The following is a description of a gene set: studied in species Homo sapiens A discrete abnormal tissue mass that protrudes into the lumen of the intestine and is attached to the intestinal wall either by a stalk, pedunculus, or a broad base. Intestinal polyp Human Gene Set: HP_INTESTINAL_POLYP, and this is the list of marker genes: POLD1, MTOR, PIK3CA, KRAS, BUB3, PMS1, SDHC, BUB1B (BUB1 mitotic checkpoint serine/threonine kinase B), CTNNB1, STK11, MSH6, CHEK2, ENG (NCBI Gene Id 2022), BUB1, GPR101, FLCN, PTCH1, TRIP13, TP53, DICER1 (dicer 1, ribonuclease III), APC, PDGFRA, CEP57, PMS2, MSH2, MLH1, BMPR1A (NCBI Gene Id 8035), SEC23B, AXIN2, MSH3, MBD4, AIP, USF3, KLLN, PTEN, NTHL1, EPCAM, GREM1, KEAP1, SDHD, SMAD4, ACVRL1, MUTYH, POLE, GNAS, RNF43, AKT1, MDM2, HEPACAM, GDF2, CDKN2A, SDHB, TGFBR2